The following is a description of a gene set: species: Homo sapiens from publication Chen Y, Wang X (PMID 31504780) Human Gene Set: MIR4681 Genes predicted to be targets of miRBase v22 microRNA hsa-miR-4681 in miRDB v6.0 with MirTarget v4 prediction scores > 80 (high confidence targets)., and this is the list of marker genes: RPP14, ZSCAN23, CDC20B, AP3D1, SNRPB